Given this list of marker genes Pbrm1, Dpf1, Hsf1, Recql5, Senp3, Zcwpw1, Bcl7a, Rnf126, Polq, Rnf169, Vps72, Spidr, Terf2ip, Parp3, Wrap53, Fbh1, Morf4l1, Ubqln4 (ubiquilin 4), Smarcb1, Bcl7c (B cell CLL/lymphoma 7C), Khdc3, Usp51, Dpf3, Helq (helicase, POLQ-like), Hdgfl2, Rpa2, Aunip, Kdm4d, Mbtd1 (mbt domain containing 1), Brd8, Prmt1, Fmn2, Pot1b, Trrap, Prkdc, Dmap1, Phf10, Setmar, Mad2l2, Kmt5a, Smarcd1, Ooep (NCBI Gene Id 67968), Shld2, Actl6a, Ep400, Ddx11, Kmt5c, Morf4l2, Smchd1, Actb (actin, beta), Cgas, Ube2v2, Brd7, Hmga2 (high mobility group AT-hook 2), C1qbp, Ppp4r2, Ppp4r3c1, Ppp4r3a, Mgmt, Meaf6, Klhl15, Timeless, Nbn, Ppp4r3b, Fignl1, Fh1, Was, Kat5, Slf1, Nsd2, Tex15, Nudt16l1, Actl6b, Shld1, Otub1, Radx, Dek, Actr2, Blm, Parp1, Smarcc2, Smarca2, Ager (advanced glycosylation end product-specific receptor), Rtel1, Peli1, Smarcd3, Smarce1, Chek1, Twist1, Skp2, Zfp365, Bcl7b, Epc1, Fus, Rmi2, Pnkp, Kmt5b, Arid1a, Rif1, Mrnip, Kdm1a, Pot1a, Ruvbl1, Ing3, Ppp4c, Atrip, Epc2, Dpf2, Spire1 (NCBI Gene Id 68166), Slf2, Setd2, Ogg1 (8-oxoguanine DNA-glycosylase 1, NCBI Gene Id 18294), Yeats4, Top2b (topoisomerase (DNA) II beta), Ppp4r3c2, Sirt1, Smarcd2, Spire2, Crebbp, Foxm1, Arid2, Atm, Trp53bp1, Pias4, Fancb, Helb, Plk1, Smarcc1, Parpbp, Rad51, Wdr48, Csnk2a1, Ube2n, Mrgbp, Pml, Ercc6, Rnf8, Sirt6, Rad51ap1, Abl1, Mre11a, Cyren, Atr, Smarca4, Ruvbl2, Shld3, here is a description of the gene set: Mouse Gene Set: GOBP_REGULATION_OF_DOUBLE_STRAND_BREAK_REPAIR Any process that modulates the frequency, rate or extent of double-strand break repair. species: Mus musculus